Given this list of marker genes CARF, POU3F2, DNMT3A, KRT26, CDC27, TCF21, MYO3B, ELAVL1, PTPN11, NLK, ZNF569, PLAC8, NEFL, SLC45A3, STOX2, CELF5, MMP1, BRD3, PRKCB, SLAIN2, TDRD15, SMURF2 (NCBI Gene Id 64750), USP15, NRAS, KCNB1, IL17A, BSDC1, ILF2, ARNT2, PNMA5, BCL2A1, SLC9A6, PRKG2, PRKAR1A, YIPF6, NR4A3, SOX9, EML2, CSDE1, CLIP3, UBE2D1, KLF14, HSPB7, SLC22A3, TMEM132D, KIAA1671, ZFAND5, PROS1, MIS18BP1, TRIM66, SIAE, ADAM29 (ADAM metallopeptidase domain 29), FAM53A, TRIM34, PRKAA1, ITPRID1, ACADSB, KIAA0232, CACNA1E, ASB9, TRIM6-TRIM34, MBTPS2, CAMTA1 (calmodulin binding transcription activator 1), TLN1, TMEM167A (transmembrane protein 167A), CHCHD4, ZMYND11, TCEAL7, here is a description of the gene set: Genes predicted to be targets of miRBase v22 microRNA hsa-miR-514a-5p in miRDB v6.0 with MirTarget v4 prediction scores > 80 (high confidence targets). from publication Chen Y, Wang X (PMID 31504780) studied in species Homo sapiens Human Gene Set: MIR514A_5P